The following is a description of a gene set: studied in species Mus musculus Any process that activates or increases the frequency, rate or extent of epidermis development. Mouse Gene Set: GOBP_POSITIVE_REGULATION_OF_EPIDERMIS_DEVELOPMENT, and this is the list of marker genes: Cyp27b1 (NCBI Gene Id 216437), Sfrp4, Sfn, Krt10, Sult2b1, Ptch1, Ptch2, Ppard, Prkch, Pkp1, Fgf2, Tmem79, Foxc1, Ovol2, Notch1, Bmp4, Vdr, Macroh2a2, Elapor2, Med1, Numa1, Alox8, Ncoa3, Macroh2a1, Nme2, Krt2, Kdf1, Etv4, Atoh1